The following is a description of a gene set: species: Homo sapiens Renal hypoplasia Human Gene Set: HP_RENAL_HYPOPLASIA Hypoplasia of the kidney., and this is the list of marker genes: RAP1B, VPS37D, FGFR3, ATP5MK, DHCR7, DYNC2H1, DNAJC30, RPS19, REN (renin), BAZ1B, TBX3, NRIP1, FANCI, ZPR1 (NCBI Gene Id 95155), DYNC2I2, FAT4, CEP55, GTF2I, ITPR1, GTF2IRD1, MLXIPL, PUF60, TMEM67, MCM5, ARID1B, KYNU, MT-ATP6, ZNF699, ATP5F1E, WDR35, METTL27, HMGA2, SALL4, FKBP6, RNU4ATAC, EIF4H, B3GLCT, NIPBL, LEMD3, TBX1, FRAS1 (Fraser extracellular matrix complex subunit 1), MBTPS2, H4C3, KDM6A, STX1A, RFC2, SKIC3, BMP4, ERCC8, GEMIN4, LIMK1, FREM2, STRA6, SEC24C, PRIM1, CLIP2 (CAP-Gly domain containing linker protein 2), FGF10, HIRA, ERCC6, INTU, TBX18, ELN, SALL1, SEC61A1, TBL2, HAAO (NCBI Gene Id 23498), DLL4, GLI3, PAX2 (NCBI Gene Id 5076), DCDC2, NOTCH2, PPP1R15B, DCHS1, SKIC2, ROBO2, GP1BB, FANCF, PDE6D, NSD2, HNF1B, KCNJ5, COX14, NFIA, ARVCF, BUD23, UFD1, TMEM270, ATRX, NODAL, CENPF, LRP4, KIF14, HSPA9, NCAPG2, JMJD1C, RERE, C2CD3, KCNJ2, FBXW11, FANCL, AFF3, KMT2D, SRRM2, TXNL4A, CHD7, KCTD1, ATN1 (atrophin 1), MUC1, IFT27, PIEZO2, JAG1, IFT80, PIK3CA, RAD21, SLC30A9, DYNC2I1, RFWD3, RARB, WDR19, ARL6, WNT7B, NAA10, RREB1, DACT1, ATPAF2 (ATP synthase mitochondrial F1 complex assembly factor 2), FGFR2, MYOD1, HRAS, TRRAP, ATP5F1A, PRMT7, PLXNA1, COMT, MDM2, PQBP1, ATP5F1D, XRCC4, RMND1, MT-ATP8 (NCBI Gene Id 4509), NCF1 (NCBI Gene Id 653844), BCOR, UMOD, PBX1, H4C5, DSTYK, GTF2IRD2, CEP120